The following is a description of a gene set: Mouse Gene Set: GOBP_POSITIVE_REGULATION_OF_ALPHA_BETA_T_CELL_ACTIVATION species: Mus musculus Any process that activates or increases the frequency, rate or extent of alpha-beta T cell activation., and this is the list of marker genes: Nfkbid, Cd1d2, Prkcz, Anxa1, Itpkb, Card11, Pnp, Nfkbiz, Tgfbr2, Syk, Lilrb4a, Hsph1, Blm, Tyk2, Gli3, Il4ra, Ap3b1, Irf1, Shh, Brd4, Cd55b, Klhl25, Il23a, Il2rg, Rara, Ripk2, Cbfb, Gimap3, Nkap, Ep300, Cd83, H2-Ea, Rhoa, Opa1, Ifng, Ada, Brd2, Cd244a, Cd24a, Il18, Gimap5, Cd1d1, Nckap1l, Ptpn22, Sash3, Runx3, Cd55, Runx1, Rasal3, Foxp3, Mir326 (NCBI Gene Id 723840), Cd80, Zbtb7b, Xcl1, Cd81, Ccl19, Ap3d1, Cd160, Socs5, Cd28, Il12b, Ccr2, H2-T23, Nlrp3 (NCBI Gene Id 216799), Irgm1, Malt1, Il12a, Prkcq, Hlx, Zap70, Ihh, Ptprc, Lilrb4b, Tnfsf4, Il6, Cd3e, Socs1, Ccr7, Jak2, Shb